The following is a description of a gene set: Human Gene Set: GOCC_NUCLEAR_INCLUSION_BODY An intranuclear focus at which aggregated proteins have been sequestered. studied in species Homo sapiens, and this is the list of marker genes: NUP98, RANBP2, ATXN3, NBN, RAD18, NXF1, SLF1 (NCBI Gene Id 84250), PABPN1, TPR, STUB1 (NCBI Gene Id 10387), ATXN1, NUP153